The following is a description of a gene set: studied in species Homo sapiens Human Gene Set: HNF1_Q6 Genes having at least one occurrence of the motif WRGTTAATNATTAACNNN in the regions spanning 4 kb centered on their transcription starting sites. This matches the TCF1 transcription factor binding site V$HNF1_Q6 (v7.4 TRANSFAC)., and this is the list of marker genes: AGTR2, PPP1CB, DPYD, AXIN2, FGA, SEMA4G, ZNF827, RNF186, RARB, ALX1, MRPL28, TOP3B, ARL4C, PCBP1 (poly(rC) binding protein 1), BPIFA1 (NCBI Gene Id 51297), PRDM1, WNK1, ALB, ZBTB4, KRT25, OPRM1, PAK4, SLC5A4, NTF3, OLFM4, SPATS2, TMEM88, RORA (RAR related orphan receptor A), SALL3, RNASE4, POU3F2, ISL1, SLCO1B1, AFM, NRXN3, ESD, RASSF7, PLAG1, TULP4, RASGRF2, FAM27E5, OR2W1, AQP9, AOC2 (NCBI Gene Id 95864), FIBIN, SOX18, PURA, TENM1, CBFA2T2, KCNK18, CLOCK (NCBI Gene Id 9575), SULF2, CCND2, F13B, CXCL3, CS, PDE4D, SRSF6, SLC7A13, DCUN1D1, VSIG1, ELF4, GEN1, HGFAC, RUNX1, SATB2, BCL11A, PLG, ANGPTL3, EGR1, TFEC, MBNL2, ARPP21 (NCBI Gene Id 51183), PDLIM1, HAO1, LIPC, SRSF7, USP3, PPP1R2B, SLC12A2, ZNF22, ERRFI1, UGT1A6, HTR7, NFIX, GAS2, SGK2, MYRF, CDH16, NOG, RAB3IP, TMPRSS15, MMP27, PBX2, TLE4, COL4A5, CLDN10, HOXB3, UGT1A1, ZFPM2, PHOX2B, CNTLN, PAX2, GOLT1A, CYFIP2, SLC13A2, DAAM1, UGT2A3, SERPINA7, FAM20C, MAP2K5, CITED2, NPAS2, ZNF22-AS1, GUCA2B (NCBI Gene Id 2981), C1orf116, CLC, GAN, NCOR1, SLC39A14, PKHD1, ANPEP, FGFR4, LPAL2, ERG, RBM47, BCL9, GANC, SLC7A9, MGAM, AFP, CYRIA, KLK13, STAG2, MTTP, TBR1, MPRIP, LMNTD2, SPATA18, CTTNBP2NL, HOXC4, KRT26, PDZRN4, PPARGC1A, HABP2, MED12L, ADAM11, NAPSA, SI, CYP2E1, TTLL6, HNF1B, POU2F1, SERPINA10, ANXA13, PDGFRA, KBTBD12, TRDN, DDX17, FAM117B, NRK, HPN, ARF6, FGB, TM4SF4, SLC39A5, LINC00671, CLTRN, CFI, PPP2R2B, F2RL1 (F2R like trypsin receptor 1), HEXIM2, SPINK1, SLC44A3, RREB1, FLI1, MOSMO, SLC4A4, C8A, RBMS1, CHCHD7, MIA2, HNF1A, HNRNPR, ZEB2, PRODH2 (NCBI Gene Id 58510), BPHL, CSF3 (NCBI Gene Id 170794), ZMYND8 (NCBI Gene Id 55497), LUC7L3, SLCO5A1, CTCF, FOXP2, PPFIBP1, NCKAP5, LPP, TMED6, GGCX, SLC5A1, LRRFIP2, POLR2A, TBX2, COL4A6, OVCH2, SAMD11 (NCBI Gene Id 148398), SERPINA4, CES5A, IGFBP1, HOXD10, APOM, GJB1, ASPA, MYO18A, SEMA3A (NCBI Gene Id 63232), PHLDB1, FXYD2, PPP2R5C, CLUH, NR1H4 (NCBI Gene Id 9971), ZIC2, C5, DMD, CREB5, TMEM87A, MSH5, TCF12, FOXG1, G6PC1, HOXB9, ARHGAP24 (NCBI Gene Id 83478), ATP11AUN, KLF14, KCP, ACVR2A, PPP1R3A, BMI1, PRICKLE1, RORB, DLX1, GC, NRP1, CRB3, F2, ROBO3, TBXAS1, HNF4A, SERPINA6, TMEM187 (transmembrane protein 187), SFRP4, CLRN1, KLB, HOXA10, HOXC6 (homeobox C6), PNMA1, TINAG, CDH17